Given this list of marker genes GLUL (NCBI Gene Id 2752), NRK, ZNF567, CCDC140, COL25A1, RANBP3L (NCBI Gene Id 202151), STMP1, RAB41, BAZ1B, GBE1, ROCK1, DDX19A, ARMCX3, KCNE1, RS1, KANK2, NLGN1, SEPTIN7, SET, SP1, TMED5, TM9SF4, FECH, AMER2, MARCHF7, SERBP1, FAXC, ABRAXAS2, MTF2, TBR1, TIAL1, CHCHD7, CEP192, CD200R1, BTG1, GCSAML, SLC5A3, SLC6A15, RBMX, PRELP (proline and arginine rich end leucine rich repeat protein), SLC25A14, ABCA3, PLAC8, P2RY13, PIGN, PIK3R1, ZFYVE19, AUTS2, ACACA, RICTOR, SLC6A17, ATAT1, here is a description of the gene set: from publication Chen Y, Wang X (PMID 31504780) studied in species Homo sapiens Genes predicted to be targets of miRBase v22 microRNA hsa-miR-7151-5p in miRDB v6.0 with MirTarget v4 prediction scores > 80 (high confidence targets). Human Gene Set: MIR7151_5P